Given this list of marker genes Camk2g, Slc8a2, Fxyd2, Fkbp1b, Itpr3 (NCBI Gene Id 21779), Nppc (natriuretic peptide type C, NCBI Gene Id 18159), Calm2, Fxyd6, Atp2b3, Atp2b1, Atp2a2, Kcnip4, Camk2a, Pln, Fxyd4, Cacng8, Itpr2, Camk2b, Atp1a1, Kcne4, Tnni3, Cacna1c, Kcnq1, Cacng6, Cacna2d2, Kcnh2, Slc8a3, Kcnk7, Atp1b2, Kcnk10, Itpr1, Kcnk4, Fxyd1, Kcnk9, Cacnb2, Dmpk, Nppa, Kcnk5, Sri, Cacng4, Kcnk6, Atp1b1 (NCBI Gene Id 11931), Kcnk15, Kcnk12, Atp1a3, Ryr1, Ryr2, Ryr3, Kcnj11 (potassium inwardly rectifying channel, subfamily J, member 11), Ces1d, Calm3, Npr1, Akap9, Trpc1, Kcnk2, Kcne2, Fxyd3, Kcnk18, Atp2b4, Kcnip1, Atp2b2, Kcnk3, Calm1, Kcnj2, Kcnip3, Mme, Cacng7, Kcna5, Atp2a1, Kcnd3, Abcc9, Camk2d, Kcne3, Kcnk13, Corin, Trdn, Casq2, Ahcyl1, Stim1, Kcnj4, Kcne5, Nos1, Slc8a1, Kcnd2, Casq1, Npr2, Atp1a2, Asph, Kcnd1, Atp2a3, Kcnk1, Kcnj12 (NCBI Gene Id 16515), Atp1a4, Kcnip2, Fxyd7, Kcnj14, Kcnk16, Atp1b3, Cacnb1, Prkaca, here is a description of the gene set: studied in species Mus musculus Mouse Gene Set: REACTOME_CARDIAC_CONDUCTION Cardiac conduction